The following is a description of a gene set: Reactome Pathway: Activation of NIMA Kinases NEK9, NEK6, NEK7 This event has been computationally inferred from an event that has been demonstrated in another species.<p>The inference is based on the homology mapping from PANTHER. Briefly, reactions for which all involved PhysicalEntities (in input, output and catalyst) have a mapped orthologue/paralogue (for complexes at least 75% of components must have a mapping) are inferred to the other species. electronically inferred by orthology from the curated human pathway part of: Nuclear Envelope Breakdown species: Mus musculus, and this is the list of marker genes: Plk1, Ccnb1, Cdk1